Given this list of marker genes L1TD1, NHLH2, ARL6IP5, KLHL41, ALCAM, GAP43, ZNRD2, SGCD, LDLRAP1, FAP, CRABP1, SORBS1, MEF2C, HAPLN1, NR2F1, COL3A1, NAGK, NPR3, ST7, LPAR6, RBP1, LZTS1, FST, DCN, L1CAM, RHOB, BCHE, TAGLN3, S100A11P1 (S100A11 pseudogene 1), ANXA1, GYPC, NGFR, ZCCHC24, ENC1, DLC1 (NCBI Gene Id 94517), GNRH1, POSTN, PHOX2B, MDFI, AP1S2, AKR1C1, NAP1L1 (nucleosome assembly protein 1 like 1), TRIL, SCG3 (NCBI Gene Id 29106), LAMB1, CRYZ, BMP5, PODXL, RRBP1, ST18, TNNC2, CEBPD (CCAAT enhancer binding protein delta), LITAF, IFI16, COMMD9, SST, PITX2, MITF, NFASC, INA, COL14A1, RASL12 (NCBI Gene Id 51285), PCDH8, SCRG1, NRXN1 (neurexin 1), SNAP25, CELF3, SPP1, STMN2, CHN2, LIN28A, SH3BGRL3, SHC1, MSX1 (NCBI Gene Id 4487), TFAP2B, EDNRA, MSTN, CDH19, TMEM204, LGALS1, NNAT, GRN, IGFBP7, TFAP2A, NEFL, ARHGDIA, C3orf52, NRIP1, SNAI2, TRIM62, ROR1, HOXA2, NMRK1, KCNN2, DACT1, SLIT1, LUM, QPRT, CDH6, ELK3, PAX3, SOX10, EEF1A2, IGFBP5, CNR1, HMGA1, COBLL1, POU4F1, SCN3A, PCBP4, ZEB2, CRABP2, S100A11, SLN, DCX, ITGA4, STMN4, BGN, NEFM (NCBI Gene Id 4741), DNAJC1 (NCBI Gene Id 95528), PDGFRA, TGFBI, CDH1, KCNK5, RUNX1T1, ADGRG6, LRRN3, COL1A2, ATP1A2, NRP2, NR2F2, GSN, S100A10, EMC1, CYP26A1, PMP22, SLC17A6, XIST, HOXB2, SERPINB9, NHLH1, MOXD1, ERBB3, DPYD, STRA6, SEMA3C, CHGA, here is a description of the gene set: Vertebrate neural crest development depends on pluripotent, migratory precursor cells. Although avian and murine neural crest stem (NCS) cells have been identified, the isolation of human NCS cells has remained elusive. Here we report the derivation of NCS cells from human embryonic stem cells at the neural rosette stage. We show that NCS cells plated at clonal density give rise to multiple neural crest lineages. The human NCS cells can be propagated in vitro and directed toward peripheral nervous system lineages (peripheral neurons, Schwann cells) and mesenchymal lineages (smooth muscle, adipogenic, osteogenic and chondrogenic cells). Transplantation of human NCS cells into the developing chick embryo and adult mouse hosts demonstrates survival, migration and differentiation compatible with neural crest identity. The availability of unlimited numbers of human NCS cells offers new opportunities for studies of neural crest development and for efforts to model and treat neural crest-related disorders. Genes up-regulated in the neural crest stem cells (NCS), defined as p75+/HNK1+. studied in species Homo sapiens Human Gene Set: LEE_NEURAL_CREST_STEM_CELL_UP from publication Lee G, Kim H, Elkabetz Y, Al Shamy G, Panagiotakos G, Barberi T, Tabar V, Studer L (PMID 18037878)